Given this list of marker genes Akr1b10, Sdad1, Dgcr2, Abhd17c, Cox15, Ccdc8, Hrob, Pex7 (NCBI Gene Id 18634), Obi1, Prkra, Zfp763, Ogfod3, Zfp783, Slc22a3, Mgat5, Dtnbp1, Mrps30 (NCBI Gene Id 80449), Herc6, Ppif, Septin6, Foxk1, Slco3a1, Rnmt, Ppp1r11, Tmem161a, Nme2, Naa60, Srd5a1, Gna15, Nrros, Ppfibp1, Diras2, Bbs4, Commd7, Rnf130, Sirt3, Pard3b, Tmem98, Crtac1, Kyat3, Als2, Oxct1, Tmem201, Cenpv, Dicer1, Zfp84, Uqcc4, Ctdspl2, Nkg7, Ubash3a, Cdca7l, 4933431J24Rik, Commd1, Dbil5, Hspa9, Vps11, Lyplal1, Spr, Gatb, Gtf2a1l, Irx2, Trabd2b, Hsf2bp, Rsrc1, Chml, Tdrd3, Tubgcp5, Suv39h2, Dnajc15, Cluh, Mlec, AU040972, Zwint, Prpf40a, Zmym3, G3bp1, Dhx9, Ppm1f, Ddx18, Cdk6, Ak4, Znrf2, Sdr9c7, Prr3, Ppan, Arsb, Mrpl44, Mtrf1, Nup42, Dpagt1, Smug1, Lysmd4, Deptor, Zfp975, Gnptab, Pals2, Hpn, Nup62, Prpsap1, Lsm11, Zfp120, Arl2, Cmtr2, Mrpl45, Mcm3, Ube2q2, Ppp1r14b, Uqcc1, Opn3, Wdr12, Ip6k2, Mettl16, Tmem248, Retsat (NCBI Gene Id 97303), Gmps, Armcx4, Ankrd23, Zfp787, Ddx51, Il36b, Hdhd2, D830050J10Rik, Psmb10, Bzw2, Spred2, AU041133, Rnaseh1, Tmed10, Polr1h, Supv3l1, Srp68, Slc6a20b, Ankrd45, Utp6, Gorasp2, Taf15, Gbp7, Tdrkh, Asrgl1, Mcmbp, Vps33b (vacuolar protein sorting 33B), Atg10, A930005H10Rik, Cpsf3, Wdr36, Cd34, Kctd18, Extl2, S100a1, Gart, Gm6740, Fastkd1, Cul2, Fdx1, Exosc6, Numbl, Bbof1, Cmtm7, Cdk4, Parp1, Gria3, Fyttd1, Sfxn2, Zfp536, Gcsh, Ilf3, Ctnnbl1, BC002059, 2310039H08Rik, Mdh1, Hibadh, Pank1, Rbm34, Rabggta, Mis18bp1, Poglut1, Zdhhc9, Slf1, Spast, Shisa2, Strn4, Dmac2, Phf14, Rapgef3, Snx9, Sec61a1, Cryzl1, Fgf3, Ldlrad3, Septin11, Fam90a1a, Chn2, Clasp1, Poli, Zfp52, Zfp493, Ube2q1, Macrod1, Abhd11, Rpl18, Mir221, Cyb5b, Pdp2, Zfp994, Lpar6, Nln, Tmem218, Xkr8 (X-linked Kx blood group related 8), Rcc2, Gm16845, Umps, Alkbh1, Adamtsl1, Bckdha, Heg1, Cd69, Nxph4, H2az2, Csrp1, Lrrc59, Poglut2, Pfas, Bex6, Esd, Prep, Smim36, Arhgap6, Shisa7, Bri3bp, Ylpm1 (YLP motif containing 1), 1110059E24Rik, Dapp1, Vipr2, Ahcy, Lxn, Krtap9-3, Urm1, Snapc1, Gopc, Snapc2, Rnf157, Pdap1, 1700017B05Rik, Mrps27, Gm13446, Stam (signal transducing adaptor molecule (SH3 domain and ITAM motif) 1), Rfx7, Sinhcaf, Sostdc1, Tchhl1, Dynlrb1, 4931414P19Rik, Gtf2i, P2ry14, Manf, Elp3, Prtn3, Pdxk, Gpatch4, Pprc1, Cst7, Ube2d-ps, Ptf1a (NCBI Gene Id 54333), Klhdc9, Sucla2 (succinate-Coenzyme A ligase, ADP-forming, beta subunit), Mtmr7, Styx, Slc35a1, Odf2l, Mtmr4, Zfp11, Rmdn2, Exog, BC035044, Ggct, Ripk3, Manba, Klhl5, Patz1, Naxd, Gsto1, Cfap418, Trmt2b, Rpgr, Rbm19, Mars2, Abcc4, Ten1, Tox, Tfb2m, Elovl5, Snhg7, Trak1, Smim30, Parp8, Zfp830, Ddx28, Iftap, Chd5, Pld6, Fmc1, Rexo5, Gstm4, Tmem250, Ccdc86, Tigar, Zranb3, Macroh2a1, Ppid, Uqcc3, Psd4, Abitram, Galk2, Mgat2, Slc35b2, Lclat1, Aldh7a1, Cbfb, Adgrg3, Qdpr, Prmt6, Emilin1, Rrp7a, Pphln1-ps1, Ptger3, Lmf1, Elp6, Paox, Paqr7, Sae1, Psma8, Gmds, Sf3a2, Bckdhb, Ankle2, Slc22a17, Lbp, Kcnk12, Eef2kmt, Zzz3, Tspyl3, Slitrk1, Rps6ka5, Bcor, Abracl, Slc25a53, Ttll4, 4933404O12Rik (RIKEN cDNA 4933404O12 gene), Glb1, Pdzph1, Fbxo45, Mrps26, Dhcr7, Prdx1, Ccdc22, Cilk1 (ciliogenesis associated kinase 1), Zfp213, Creld2, Nolc1, Ddx31, Lcorl, Prpf4, Mrps12, Syce2, Vapb, Ripk1, Mfsd4a, Tiaf2, Dcp2, Mcee, Dis3l, Acsm2, Txndc12, B4galt4, Rpl22, Sugct, Pinx1 (PIN2/TERF1 interacting, telomerase inhibitor 1), Myb (NCBI Gene Id 97674), Spn, Ncl, Dlat, Slc4a8, Rasl10a, Echdc3 (NCBI Gene Id 99053), Wee1, Vma21, Gnb4, Tagln2, Arcn1 (archain 1), Idh2, Ttf2 (NCBI Gene Id 99859), Afg2b, Fzd7, Zfp748, Dcun1d4, Med14 (NCBI Gene Id 72974), Slc10a7 (NCBI Gene Id 76775), Snrpb2, Tmed4, Cand1, Bcl2, Npepl1, Ogfr, B3galt6, Ube3a (NCBI Gene Id 76097), Pitpnc1, AI429214 (expressed sequence AI429214), Map1a, Pak1, 4930544L04Rik, Ing5, Smn1, Dctd, Cux1, Prkdc, Kif21a, Bfsp2, Ppp1r13b, Fpgs, Sh2d5, Gtpbp10, Zfp383, Luc7l, Sppl2a, Pdia5 (protein disulfide isomerase associated 5), Plekha4, Pgm3, Anapc11 (NCBI Gene Id 97770), Tespa1 (thymocyte expressed, positive selection associated 1), 2810004N23Rik, Pfdn4, Zfp386, 1700015O11Rik, Sec23ip, Dbt, Abl2, Lrrc34, Slc38a10, Impa2, Gid4, Vars2, Rbm28, Riox2, Glod4, Ttll9, Snapc5, Gnpnat1, L3mbtl3, Dimt1, Socs6, Fut7 (NCBI Gene Id 99110), G6pc3, Ddx59, Atpaf1, Pacc1, Ufm1, Hspa1a, Wdfy4, P3r3urf, Rps20, Kdm2b, Cenpm, Shmt1, Dph5, Ice2, Slc25a15, Mmd, Lrp12, Ppa1, Trim13, Ramp3, Hif1an, here is a description of the gene set: species: Mus musculus Mouse Gene Set: IVANOVA_HEMATOPOIESIS_EARLY_PROGENITOR Genes in the expression cluster 'Early Progenitors Shared': up-regulated in hematopoietic progenitors from adult bone marrow and from fetal liver. from publication Ivanova NB, Dimos JT, Schaniel C, Hackney JA, Moore KA, Lemischka IR (PMID 12228721) Mechanisms regulating self-renewal and cell fate decisions in mammalian stem cells are poorly understood. We determined global gene expression profiles for mouse and human hematopoietic stem cells and other stages of the hematopoietic hierarchy. Murine and human hematopoietic stem cells share a number of expressed gene products, which define key conserved regulatory pathways in this developmental system. Moreover, in the mouse, a portion of the genetic program of hematopoietic stem cells is shared with embryonic and neural stem cells. This overlapping set of gene products represents a molecular signature of stem cells.